Given this list of marker genes RAB34, IGFBP6, SCP2, GYG1, ETFB (electron transfer flavoprotein subunit beta), MKNK2, ATP1B3, HADHB, GBE1, CPT2, ABHD5, ALDH1A1, HTRA1, UCK1, BCKDHB, CIDEC, NDUFAB1, BCAT2, JCHAIN, GDPD3, CES1, PTPRB, CHPT1, ST3GAL6, PPP2R5A, PENK, SOWAHC, GPD2, LPIN1, DHRS7, CHCHD10, PGM1, DGAT1, TMEM43, GPAM, GPX3, EIF4EBP1, ACAA1, NR1H3, DECR1, GNAI1, ADRB3, CD36, ADIPOR2, APLP2, PDHA1, ACAA2, CXCL12 (C-X-C motif chemokine ligand 12), UQCR10, GHR, NDUFV1, MCCC1, ALAD, COL6A3, NPC2, GSTZ1, ZNF703, here is a description of the gene set: Down-regulated genes from top genes out of the 324-gene signature identified in the pre-neoplastic tissue adjacent to the mammary tumors induced by transgenic expression of ERBB2. from publication Landis MD, Seachrist DD, Montañez-Wiscovich ME, Danielpour D, Keri RA (PMID 15897883) Human Gene Set: LANDIS_ERBB2_BREAST_PRENEOPLASTIC_DN studied in species Mus musculus Upregulation of HER2/ErbB2/Neu occurs in 15-30% of human breast cancers and correlates with poor prognosis. Identification of ErbB2/Neu transcriptional targets should facilitate development of novel therapeutic approaches. Development of breast cancer is a multistep process; thus, to identify the transcriptomes associated with different stages of progression of tumorigenesis, we compared expression profiles of mammary tumors and preneoplastic mammary tissue from MMTV-Neu transgenic mice to expression profiles of wild-type mammary glands using Affymetrix microarrays. We identified 324 candidate genes that were unique to ErbB2/Neu-induced tumors relative to normal mammary gland tissue from wild-type controls. Expression of a subset of these genes (82) was also changed in the preneoplastic mammary glands compared to wild-type controls, indicating that they may play a pivotal role during early events of ErbB2/Neu-initiated mammary tumorigenesis. Further analysis of the microarray data revealed that expression of several known transforming growth factor (TGF)-beta target genes was altered, suggesting that the TGF-beta signaling cascade is downregulated in ErbB2/Neu-induced tumors. Western blot analysis for TGF-beta-Receptor-I/ALK5 and immunohistochemistry for TGF-beta-Receptor-I/ALK5 and phosphorylated/activated Smad2 confirmed that the Smad-dependent TGF-beta signaling cascade was inactive in these tumors. Although absent in most of the tumor, phosphorylated Smad2 was present in the periphery of tumors. Interestingly, presence of phosphorylated/activated Smad2 correlated with expression of Activin-Receptor-IB/ALK4, suggesting that although Smad-dependent TGF-beta signaling is absent in ErbB2/Neu-induced tumors, Activin signaling may be active at the leading edge of these tumors. Cumulatively, these data indicate that the TGF-beta pathway is intrinsically suppressed in ErbB2/Neu tumors via a mechanism involving loss of TGF-beta-Receptor-I/ALK5.